Given this list of marker genes NAP1L3, EZH1, CRX (NCBI Gene Id 1406), RELA (RELA proto-oncogene, NF-kB subunit), H3C15, H1-7, PSIP1, H1-10, RAD51 (NCBI Gene Id 5888), MYOG, DNMT1, SETSIP (NCBI Gene Id 648081), CENPA, MEIOB, CBX4, MSL2, NR1H3, POLE, ERCC4, BRD2, LRWD1, PITX2, SUPT16H, GATA1, BEND6, TOX, EXO1, AJUBA, BRD4, TTF1 (transcription termination factor 1), UXT, FOXO3, CAMTA2, MED12, RBMX, ACTB, ARID3C, RCOR1, RAD21, TPR, PHF10, ZNF276, FOSL1, TSPY3, NFIA, BCAS3, SSBP1, DHX30, HOXC13, DHX9, SKOR2, NEUROD1, SMAD2, MTA3, CREB3L1, RAD21L1, CCNT2, ORC1, MCMBP, PRKCB, RNF8, SUPT6H, EPOP, CDK9, SOX15, SMARCC1, MBD2, PLAC8, MED1, DDX1, SCML2, ZC3H4, ATXN1, ERCC6 (NCBI Gene Id 282965), SET, NR5A2, CDYL, TTC5, TRIM28, CDK1, REST, COQ7, GABPA, MORC2, TBR1, EBF2, SOX9, RBL1, NUP98, KDM6B, NOC2L, STAG3, ARX, ACTL6B, PRDM14, STPG4, GTF2F1, OGT, KDM1A (lysine demethylase 1A), TNRC18, CBX6, RBPJ, KLHDC3, FOXO1, SMARCB1, MSH2, NFKB1, TSHZ3, HMGA1, SIRT2, TOX3, POLR3G, MCM9, NAP1L2, KAT6A, H3-3A, EHMT2, AUTS2, TFAM, MEF2A, PAF1 (NCBI Gene Id 54623), CKS2, TASOR, CHD8, TOP2B (NCBI Gene Id 7155), NPM2, TOX2, MPO, RUNX2, TAF10, SIN3A, ZNF304, PRDM13, SMARCC2, PUS1, YBX1, SMARCA2, NPM3, PRDM15, LEF1 (NCBI Gene Id 51176), APBB1, PATZ1, SAFB, CSNK2B, HNF4A, PPARG, OVOL2, ZNF683, PHC1, KAT6B, SOX14, PRDM1, TLE4, FOXA1, NUCKS1, ASF1A, TSPYL1, TSPYL2, CENPS (NCBI Gene Id 378708), MLH1, TRIM37, VCX, ELK4, POU4F1, CEBPB, INSM1, PBX2, STAT3, KAT8, RAD17, ONECUT1, ARID1B, NAP1L4, ATAD2, THRA, RPA1, ZFP57, HDAC5 (histone deacetylase 5), SMARCD3, ERCC3, VRK1, NFAT5, NKX6-1, IRF3, RBL2, RARG, AR, POLA1, GMNN, PRMT6, GATAD2B, CBX2, BMI1, PWWP2A, CHAF1B, SIRT6, SMAD6, ERG, H1-6, POLR2B, RARA, KAT5, RIT2, SCMH1, DLX1, DNTTIP1 (deoxynucleotidyltransferase terminal interacting protein 1), PBRM1, CBX1, ATAD2B, GLYR1, ZIC2, L3MBTL1, L3MBTL2, SP3, TOP2A, BAHCC1, SUZ12, ASCL1, SCML4, SIRT1, PROP1, FOXN4, MITF, NRL, KMT5B, SHMT2, NOC3L, MSH6, HES1, CREBBP, KDM4D, IKZF5, WDR82, MPHOSPH8, TDRD3, BAHD1, PRKAA1, YY1, HESX1, ELK1, BRDT, ZEB1, WBP2, UBE2T, TFAP2B, NKAP, TADA2B, WBP2NL, RCC1, H2AZ1, GRWD1, RNF169, CITED2, POU4F2, TOP1, EGFR, KLF4, CHD2, MBTD1, FOXC1, RBPJL, MLLT1, KMT5C, SMAD3, DLX3, NUP62, RNF2, TSPY1, MTF2, H1-4, ACTRT1, ENY2, HMGN2, MEOX1, RUVBL2, TSPY4, CTCFL, HNRNPU, TAF2, SSRP1, MSGN1, NR3C1, FOS, FMR1, SLC30A9, HDAC7, TSPY8, ZKSCAN3, FOXO4, L3MBTL3, CENPF, NR5A1, SATB2, WAC, TSPY2, H1-2, ASXL1, RBBP4, POLR3D, VAX1, E2F4, NPM1, REC8, TGIF1, DDX5, CCNT1, STAT1, BAP1, ACSS2, CALCOCO1, NIPBL, HOXD10, PKN1, NCOA5, GATA6, CBX8, CTBP1, MBD3, ZNF609, SBNO2, PELP1, PARP1, TFAP2A, SVEP1, NONO, H1-9P, H1-5, ASH1L, ESR1, SUPT5H, CHD1, KMT2A, ARID3A, XBP1, SAMD11, GTF2H1, CHD6, MLLT3, KAT2B, PER1, SPI1, H1-8, SAMD1, PRDM8, AHDC1, PPARGC1A, NSD1, HOXD13, TSPY10, STAT5B, H3C14, NUDT21, FEZF2, NELFA, RERE (arginine-glutamic acid dipeptide repeats), PCGF2, PCLAF, PYGO2, ACTN4, PHC2, RING1, RNF168, ARID1A (AT-rich interaction domain 1A), FAAP24, HPF1, SMARCA4, POLR2A, APP (amyloid beta precursor protein), URI1, SREBF1, CREB3, L3MBTL4, TOX4, GTF2B, MECP2, TSPYL5, CDC6, MACROH2A2, TICRR, GLI3, WDHD1, DLX2, PRKAA2, ANKRD17, SCML1, RAN, ATF4, CASC11, SIX1, EP400, NCOA1, FOXC2, H1-0, IKZF3, HSF1, NCOA6, CHD1L, ZC3H12A, KDM6A, ATXN1L, SETD7, NCOR2, HINFP, ZNF354B, UTY, TSPY9, ATOH1, CITED1, CDC45, CHAF1A, SMARCE1, SMARCAD1, SFMBT2, HDAC2, POLE3, DNAJC2, PRDM11, SNAI2, MYOD1, SAMD7 (NCBI Gene Id 344658), RNF4, FANCM (NCBI Gene Id 57697), H3-3B, REPIN1, SKIL, H3C13, NDN, CABIN1 (NCBI Gene Id 26293), ERCC1, BRD3, MORF4L1, TSPYL4, FUS, HNRNPC, CBX5, IFT74 (NCBI Gene Id 80173), HDAC3, POLR3A (RNA polymerase III subunit A), PRIMPOL, MTA1, MAPK15, MTA2, H1-3, UBTF, ADNP, NFATC2, ATF5, STAG1, USP51, MCM8, CTCF, KDM3A, PHF21A, MACROH2A1, UPF1, GRHL3, SFPQ, JDP2, HIRA, JMJD1C (jumonji domain containing 1C), YAP1, STAG2, APTX, PKNOX1, JUN, NUPR1, NEUROG3, DPPA4, NSD2, CDCA5, DMRT1, PCBP2, CLOCK, HDAC1, HP1BP3, TP63, CIC, PTF1A, H3Y1, MEIS1, BCL6, NEUROG1, LDB1, KAT7, NCOA2, HMGN4, ZNF431, CBX3, CEBPA, SFMBT1, CRAMP1, TADA2A, TRIM24, ZNF274, VAX2, GLI2, MBD5, ZNF445, DDX11, CHD3, ISL1, HMGN5, KDM5A, CENPB, FLI1, LHX2, PARP2, CDT1, PHF19, EED, SIRT7, EGR2, POLR1A, SMC1A, HNRNPD, SIN3B, CGAS, ZNHIT1, PCGF1, JARID2, SMC4, H3-5, SMARCA5, MEN1, ACTR6 (NCBI Gene Id 64431), SUV39H1, POLD1, MBD6, PDX1, GRHL1, SMC2, TTC21B, SBNO1, SARNP, RXRB (retinoid X receptor beta), RNF20, HNF1B, MRNIP, EGR1, PCNA, SMARCA1, SOX10, SETDB1 (SET domain bifurcated histone lysine methyltransferase 1), ZNF750, NELFE, ING5, NKAPL, GPER1, DPPA2, KDM3B, DNMT3A, GRHL2, MLH3, CHD4, FABP1 (NCBI Gene Id 2168), SMARCD2, MLLT10, TCF7L2, WDR13, GLI1, OBI1, SMC3, SAP30L, PHF13, RAG2, PHF8, SRF, KLF14, MCM3AP, POLG, EOMES, TP53, HELLS, HMGA2, SMAD4 (NCBI Gene Id 4089), ASXL2, ING2, H1-1, EP300, TSPYL6, ATF2, NR1H2, CTNNB1, HR, GMNC, PHC3, APEX1, NOTCH1, NCAPH, HMGN3, GADD45A, SMARCD1, KAT2A, NCAPH2, FOSL2, THRB, MNT, GATA2, MLLT6, PHF1, TAL1, NAP1L1, HMGN1, NKX2-5, POLQ, AIRE, NFE2L1, CHD5, BARX2, CHD7, ASXL3, PAX6, KDM8, ARID5A, EZH2, ACTL6A, PWWP3A, ZFX, ATRX, HCFC1, here is a description of the gene set: studied in species Homo sapiens Human Gene Set: GOMF_CHROMATIN_BINDING Binding to chromatin, the network of fibers of DNA, protein, and sometimes RNA, that make up the chromosomes of the eukaryotic nucleus during interphase.